Given this list of marker genes HAL, GLUD1, GPT2, FTCD (formimidoyltransferase cyclodeaminase), UROC1, AMDHD1, here is a description of the gene set: Human Gene Set: WP_AMINO_ACID_METABOLISM_PATHWAY_EXCERPT_HISTIDINE_CATABOLISM_EXTENSION Amino acid metabolism pathway excerpt: histidine catabolism extension species: Homo sapiens